Given this list of marker genes TAF1A, RPS7, IDH3A, HEMGN, UBP1, ITGB7, PADI2, ABHD17C, PTBP2 (polypyrimidine tract binding protein 2), CD96, KLHL12, LANCL3, TOB1, ZDHHC2, RANBP2, RIF1, NTAQ1, TEX9, QTRT2, DTX4, ABCC4, DLD, HEY2, UNKL, PIEZO1, ARRDC4, BET1L, SYPL1, MOB1B, CALU, KCNB1, DLL1, RNF128, APP, GOLPH3, LYPD6B, ZBTB1, SNX24, PXYLP1, CDK17, CCL5, GPR171, UBASH3B, UGCG, SRF, DISP2, METAP1D, PRELID3B, POU2F1, RMND5A, PLCXD2, MTMR10, APBA2, NIPBL, SORL1, ITGB1, NOMO1, FKBP3 (NCBI Gene Id 2287), PRKAB2, LDLRAP1, CD7, UBQLN1, BIN1, FAM117B, MORN2 (NCBI Gene Id 732175), ALDH4A1, CH25H, FAM241A, RNF144A, MYO7A, HLA-DOB, PGRMC1, GARIN4, MYB, TMEM79, KCMF1 (NCBI Gene Id 57734), WDR5, FAM204A, PFAS, CTDSPL2, TRAK1, SRSF10 (serine and arginine rich splicing factor 10), RBM47, RNF145, ACOT9, COQ2, PTTG1IP, NAA30, RAB33B, SWT1, SMPD4, ARMCX1, SFR1, RBM27, STK10, H1-7, LIPF, ARL4A, ANTXR1, FBXO45, FCGR2A, ABCC12, TWSG1, ARFRP1, MUC16, GPR174, RBM7, HEATR5A, CDC14A, ATP8B4, MYLIP, LRRC40, YBX1, PRPF38B, RGS10, CHSY1 (NCBI Gene Id 22856), CDKN2AIP, ZBTB20, BACE1, ELF2, EXOC3L4, TMBIM1, SPP1, CAPN7, MAP4K4, UBXN10, UBE2Q2, DUT, SDAD1, ESF1, ASGR2, SCFD2, TSC22D1, HNRNPH1, MAP4K5, GPR160, EMB, AVL9, RPL30, RNGTT, C1QTNF9, RHOBTB2, CHST8, PGAP1, MEX3B (mex-3 RNA binding family member B), TCEAL9, RPS6KA5, PTP4A2, KLRK1, FAM107B, NRK, CYP7A1, KIAA0930, C19orf38, TRUB1, DMRT2, CPM, PDE7A, KCNG2, IQGAP2, BTG1, NEPRO, LTBP1 (NCBI Gene Id 4052), RANBP9 (NCBI Gene Id 10048), ORMDL3, HERPUD2, NME4, FRAT2, KLC4, DMRTA1, HNRNPF, HNRNPA3, GABRG2, STK17B, MARCKS, MYORG, MATN2, TUBA1A, CFAP47, UPK1B, CHCHD4, UBE2D2, ZBTB43, MAP3K4, STK26, RAD17, S100B (NCBI Gene Id 6285, S100 calcium binding protein B), AHNAK (AHNAK nucleoprotein), THRAP3 (NCBI Gene Id 9967), GPR17, BBS9, THUMPD1, CRTAM, DYRK3, SLC25A26, CACNA2D2, ZNF263, HVCN1, ARSB, CTBP2, here is a description of the gene set: Genes up-regulated in comparison of memory CD8 T cells versus those treated with IL4 and IL7. Human Gene Set: GSE32423_CTRL_VS_IL7_IL4_MEMORY_CD8_TCELL_UP Effects of IL-4 on CD8 T cells functions are largely unknown. IL-4 induces survival and proliferation of CD8 T cells, but several studies suggest that IL-4 could also affect several functions of CD8 T cells such as cytotoxicity. Our team has shown that IL-4 repress the expression of Ccl5 in vitro. To define more precisely the impact of IL-4 on CD8 T cells, we performed a whole genome expression microarray analysis of naive and memory CD8 T cells cultured in presence or absence of IL-4. This approach allowed us to define the IL4-gene-expression signature on CD8 T cells. from publication Ventre E, Brinza L, Schicklin S, Mafille J, Coupet CA, Marçais A, Djebali S, Jubin V, Walzer T, Marvel J (PMID 22942430) species: Homo sapiens